The following is a description of a gene set: species: Homo sapiens Any process that activates or increases the frequency, rate or extent of RNA splicing. Human Gene Set: GOBP_POSITIVE_REGULATION_OF_RNA_SPLICING, and this is the list of marker genes: U2AF2, SETX, DYRK1A, HSPA1A, RBMY1E, SLC39A5, RBMY1A1, RBMXL1, CELF3, PIK3R1, ERN1, CIRBP, NUP98, PRMT5, UPF1, UPF3A, HMX2, SLC38A2, TRA2A, ZPR1, UPF3B, RBMY1D, SNW1, NCBP1, CELF4, CLNS1A, WDR77, NCL, HNRNPLL (heterogeneous nuclear ribonucleoprotein L like), RBM3, SRSF5, SRSF1, STH, RBMY1J, TRA2B, RBMX, PRPF19, RBMY1B, POLR2A, RBM20, THRAP3, DAZAP1, HABP4, EXOSC10, RBM22, PRDX6, RBMY1F, SNRNP70